Given this list of marker genes Hsp90aa1, Lilrb4a, Sart1, Lilrb4b, Tnfsf9, here is a description of the gene set: Any process that modulates the frequency, rate or extent of cytotoxic T cell differentiation. studied in species Mus musculus Mouse Gene Set: GOBP_REGULATION_OF_CYTOTOXIC_T_CELL_DIFFERENTIATION